Given this list of marker genes GNAZ, TTLL12, NOL3, FLRT1 (fibronectin leucine rich transmembrane protein 1), EPO, FBP1, PLA2G4C, SLC17A2, ZNF10, NR1H4, ANK1, MXRA5, RHOBTB1, LDB3, MBOAT2, H3C10, FETUB, RGS14, IMPDH1, LSS, SPC25, ZNF169, PLCL1, NEUROD2, NFATC3, S100P, NR1H3, REG1A, GRK3, GAB2, ABCC9, VPS41, RAB35, LAMC1, NPY, LINC00837, TWIST1, PHKA1, CADM3-AS1, LAMB3, GABBR2, NFIL3, GNRH1, BAP1, MATN2, ZNF8, PDZK1IP1, FZD7, ABCD3, RASSF9, FCER2, MGAT5, GUCY1A2, PRAMEF2, LCT, GPR183, APOL1, GATA6, CD38, CTNND2, CTDP1, ANXA1, RAB30, RAMP2, CHRND, PCDHGA8, GFI1, MAP3K14, FOXF2 (NCBI Gene Id 2295), ZKSCAN7, ZBTB7A, SRD5A2, BTC, ASAP2 (ArfGAP with SH3 domain, ankyrin repeat and PH domain 2), MYBPC3, MYO1E, CCL17, APOC1, PKLR, IFNA5, PPFIA2, DSC2, TBC1D1, SLCO1B1, GP9, PPOX, CRYBB3, SLC19A1, CLDN4, MKRN1, PCDH1, CDH22, HPCAL1, TRIB1, TRAM2, TUBB4B, TRIM58, MDM2, MT1X, RNASE1, GNA15, FCGR3A, TRPC1, SDS, NMU, IP6K1 (inositol hexakisphosphate kinase 1), RASGRP3, ANGPT1, SATB2, IL1RL2, PPP1R16B, ART4, H2AP, IL10RA, CD8B, EXT1, CHRD, IER2, SGCG, ESRRA, OIP5, PTK7, C5, GRM7, TTLL4, ARSF, SGCA, CDKN2D, FRMPD1, LIPC, GP5, CASQ2, ALOX15B, SMR3B, TNNC2, PPP1R37, TDO2, RRN3, P2RY2, CCR3, LY86, SLCO1A2, SP140, PTH, GFRA2, DGKQ, PPP1R12B, PTN, EXPH5, CENPI, IL24, TPM1, CEACAM5, CD47, CERNA1, IGF1, REST, PPARG, ADAM28, RRM2, SLC4A3, CDH19, ATP7B, GAB1, CEACAM7, S100A12, CTNND1, MT4, GJB1 (NCBI Gene Id 95372), TNFRSF14 (TNF receptor superfamily member 14), ZNF80, APBB1, ITCH, APOA1, TCP10L3, TP53TG1, USH2A, CXCL12, MMP11, SELENOW, DRD3, GBX2, CXCL9, DLGAP2, SEMA3F, FMOD, GREB1, NUAK1, GCNT2, SPINK4, RBBP8, MAPKAPK3, SLC12A5, RLN1, CCDC181, DSG3, TRAIP, RSAD2, HSD17B6, SPINT2, here is a description of the gene set: Human Gene Set: GSE29949_MICROGLIA_BRAIN_VS_CD8_POS_DC_SPLEEN_DN species: Homo sapiens To understand the functional relationship between brain dendritic cells (brain DCs) and other myeloid cells, we compared the gene expression profile of m/chDCs to that of bone marrow monocytes, brain microglia and classical spleen CD8+ and CD8- DCs. In order to obtain enough brain DCs for mRNA extraction, we expanded brain DCs with in vivo Flt3L treatment before purification. Genes down-regulated in brain microglia versus spleen CD8+ dendritic cells. from publication Anandasabapathy N, Victora GD, Meredith M, Feder R, Dong B, Kluger C, Yao K, Dustin ML, Nussenzweig MC, Steinman RM, Liu K (PMID 21788405)